Given this list of marker genes NNT-AS1, HIPK1, CYCS (NCBI Gene Id 54205), PNKD, AFF3, IFIT2, NDUFC1, REEP3, MRPL20, PSMD9, POLR2J, ZYX, RHEB, EGLN2 (egl-9 family hypoxia inducible factor 2), PPTC7, CAMK2G, SEC61G, TRPM7, SAP18, ADCY5, PGM2L1, SLC1A5, CISD1, LMO1, NICOL1, RBMX2, MAPK6, LTBP1, HMGN3, PSMD8, BTBD7, MAFK, KANK2, LDHB, NCS1, MRPL55, FIS1, B4GALT6, VASP, USP2, FILIP1, SAP30BP, ABR, AZIN1, TMEM14B, DNTTIP2, PTP4A1, TLE5, PRDX3, ATP5PO, MT-ND4L, NFE2L1, BOLA3, SERF2, MT-ATP8, KIF5B, DDA1 (NCBI Gene Id 79016), RBPMS2, RPSA2, DNAJC15, SUMO3, TXNL4A, ILRUN, ANXA6, SDHD, SLC25A3, ZCRB1, MPC1, RNF185, LRRC17, PPP1R3C, UROS, CSGALNACT2, PDLIM5, BAG3, AOC3 (amine oxidase copper containing 3), HINT1, FAM234A, ZSCAN16-AS1, MRPL22, AK4, COQ3, NSMCE3, VPS29, CISD2, UBL5, ABCG1, ACOT11, AP1S2, LRRC39 (NCBI Gene Id 127495), USP10, COPS9, KARS1, ACTG2, SEL1L (NCBI Gene Id 6400), AURKAIP1, MTX2, KLHDC10, EP400, TUBB, IRS2, HSPG2, EZH1, KLHL41, DNAJA4, CDS2, MFSD6, LRRC8A, GBA2, RSU1, PKDCC, ST6GALNAC5, CCDC85B, ARMC1, ROCK2, NIPSNAP2, CKMT2, AKAP9, SLAIN2, RCOR1, FGFR2, MRPL35, SELENOK, MROH8, ATP5MC1, TUFM, PSMB5, ARPC1A, CCDC124, EIF4G1, TMEM35A, SEPTIN2, TIMM13, AGL, MXI1, ATF7, CDC42, LAMC1, AP2M1, ARHGAP1, PCYT1A, STK38L, RNASEH2C, DOK6, MRPL41, MRPL13, NXN, RPP25L, MT-ND3, COL18A1, SORT1 (sortilin 1), PSMA4, PSMA7, FRY, UBE2D4, MMP24OS, CETN2, TMC5, PPP2R5A, PHPT1, ATP5MC2, PSMD1, SNTB2, PLOD2, EIF4G2, PPP2CB, MT-ND5, TCEAL3, KCNMB1, H3-3A (H3.3 histone A), ANKMY2, NDUFS6, C6orf47, RFTN1, DHX35, MANBAL, PHB1, PPHLN1, CCDC107, SLC38A1, CCN1, JMY, UQCRFS1, RNF139, MYOM1, PITX1, PACSIN2, NDUFA11, EI24, MRPL3, PIN1, REXO2, PDIA6, MDH2, TRIM69, MT-ND2, NACC2, SEC63, MSRB1, PDE3A, ARPC5L, DUSP8, COX4I1, OXCT1, PYGM, SSPN, ATP2A3, EIF3K, ADAM22, PMVK, CCN2, UQCRC1, ZNHIT1, ATP1A2, PCM1, HAGH, DNAJC10, EMC4, EDIL3, BORCS8, CRY2, BPNT2, TMEM179B, SLC26A4-AS1, COA3 (cytochrome c oxidase assembly factor 3), HSPA6, ERGIC2, PCDH18, TLN1, FNDC5, COPS5, PIM3, RGS16, RAB3A, RASD2 (NCBI Gene Id 57347), ATP5F1C, UXS1, GAMT, MRPS11, TMED8, SYPL1, ACAT1, ADCYAP1, NDUFS5, COL24A1, PIM1, IMPA1, RPL27, BANF1, SGCG, DESI2, ZNG1A, C4orf3, TYW3, OAZ1, PDE8B, KLF2, GLYR1, PCDH19, DDIT4L, RUSC2, TCTA, VCL, NDUFA12 (NADH:ubiquinone oxidoreductase subunit A12), SAE1, MAPKAPK5-AS1, CSNK1A1, BSG, here is a description of the gene set: studied in species Homo sapiens Occular cell types curated from Gautam and Hamashima et al. Multi-species single-cell transcriptomic analysis of ocular compartment regulons from publication Gautam P, Hamashima K, Chen Y, Zeng Y, Makovoz B, Parikh BH, Lee HY, Lau KA, Su X, Wong RCB, Chan WK, Li H, Blenkinsop TA, Loh YH (PMID 34584087) Human Gene Set: GAUTAM_EYE_IRIS_CILIARY_BODY_SMOOTH_MUSCLE_CELLS